The following is a description of a gene set: Mouse Gene Set: GOBP_REGULATION_OF_MYOBLAST_DIFFERENTIATION studied in species Mus musculus Any process that modulates the frequency, rate or extent of myoblast differentiation. A myoblast is a mononucleate cell type that, by fusion with other myoblasts, gives rise to the myotubes that eventually develop into skeletal muscle fibers., and this is the list of marker genes: Cxcl9, Mstn (myostatin), Smarcd1, Plcb1, Actl6b, Smarcb1, Nmrk2, Tbx3, Actl6a, Lrrc8a, Ddit3, Myod1 (NCBI Gene Id 17927), Klhl41, Cd53, Smyd1, Flot2, Ripor2, Il18, Brd7, Arid2, Smarca4, Smarcd2, Mapk14, Igfbp3, Nr2c2, Arid1a, Tnfsf14, Myocd, Tmem182, Actb, Pbrm1 (NCBI Gene Id 76748), Cxcl10, Smarca2 (NCBI Gene Id 67155), Pik3r1, Il36g, Mef2c, Cxcl14, Ccl9, Zfhx3, Mustn1, Xkr8, Sostdc1, Gdf3, Smarce1, Sox8, Hif1an, Sra1, Eid2b, Dpf3, Ankrd2, Csrp3, Dll1, Zfp36l1, Rbm24, Cdon, Capn3, Dubr, Prl2c2, Smarcc2, Ilk, Cmtm5, Map3k5, Btg1, Tnf, Ccl8, Boc, Myf5, Mkx, Kat5, Trip4, Phf10, Smarcd3, Sox9 (SRY (sex determining region Y)-box 9), Myog, Tgfb1, Notch1 (NCBI Gene Id 68125), Bmp4, Sox4 (SRY (sex determining region Y)-box 4), Ranbp3l (RAN binding protein 3-like), Id3, Ppard, Prickle1, Mbnl3, Smarcc1, Myf6, Ccl17, Akirin1, Flt3l, Neu2